Given this list of marker genes MIR34B, NOTCH2, H3C13, JUN, H2BC3, AGO2, B4GALT1, H2BC6, MIR206, RUNX1, H2AC7, ATP2A1, H2BC1, H3C7, H2BC10, H4C11, MIR150, H2AZ2, ST3GAL3, SNW1, EP300, H3C6, H2BC4, H3C8, LFNG, H2AC18, H2BC15, MAMLD1, ATP2A3, ELANE, KAT2A, RFNG (RFNG O-fucosylpeptide 3-beta-N-acetylglucosaminyltransferase), H4C9 (NCBI Gene Id 8294), MAML1, AGO4, H2BC21, RAB6A, PRKCI, H4C12, H3C12, POFUT1, TNRC6B, MIR302A, MFNG, NOTCH3, POGLUT1, NOTCH2NLC, TFDP1, H4C2, H4C16, NOTCH2NLB, H3C14, H4C4, H3C11, H3C2, H2BC12L, H2AC8 (H2A clustered histone 8), H2BC13, NOTCH1, NOTCH2NLR, H2BC5 (NCBI Gene Id 3017), H3-3B, CCND1, H2AC4 (H2A clustered histone 4), CREBBP, KAT2B, MIR449A, H2BC17 (H2B clustered histone 17), H4C13, H2AX (NCBI Gene Id 3014), MOV10, H2BC9, NOTCH4, H4C15, H2AC19, MIR200C, H4C8, MIR200B, TMED2, H2AC20, H3C1, H2AJ, H2BC7, H4C5, H2BC14, TNRC6C, H2BC8, AGO1, MAML3, H2AB1, RBPJ, H2BC26, H4C3, H3-3A, H2AC6, MIR34C, H2BC12, TNRC6A, MIR449C, AGO3, SEL1L, H2BC11, H4C14, ATP2A2, ELF3, FURIN, H3C3, H3C15, H3C4, SIRT6 (NCBI Gene Id 51548), ST3GAL6, MIR181C, ST3GAL4, H2AC14, MAML2, MIR449B, NOTCH2NLA, E2F1, TFDP2, TP53, H4C1, H3C10, E2F3 (E2F transcription factor 3), H4C6 (H4 clustered histone 6), here is a description of the gene set: Pre-NOTCH Expression and Processing Human Gene Set: REACTOME_PRE_NOTCH_EXPRESSION_AND_PROCESSING studied in species Homo sapiens